Given this list of marker genes ACADS, HADHB (NCBI Gene Id 3032), HADH, ECHS1 (enoyl-CoA hydratase, short chain 1), HADHA, here is a description of the gene set: studied in species Homo sapiens part of: mitochondrial fatty acid beta-oxidation of saturated fatty acids The sixth pass through the beta-oxidation spiral picks up where the last left off with the saturated fatty acid hexanoyl-CoA and produces butanoyl-CoA. Four enzymatic steps are required starting with SCAD CoA dehydrogenase (Short Chain) activity, followed by the enoyl-CoA hydratase activity of crotonase, the 3-hydroxyacyl-CoA dehydrogenase activity of the short chain 3-hydroxyacyl-CoA dehydrogenase (SCHAD), and completed by the ketoacyl-CoA thiolase activity, present in the mitochondrial membrane associated trifunctional protein. Reactome Pathway: Beta oxidation of hexanoyl-CoA to butanoyl-CoA